The following is a description of a gene set: Neighborhood of HLA-C species: Homo sapiens Human Gene Set: GNF2_HLA_C Neighborhood of HLA-C major histocompatibility complex, class I, C in the GNF2 expression compendium, and this is the list of marker genes: SASH3, CYTIP, STAT6, CD48, INPP5D, SUSD6, FXYD5, TAP1, PHF11, CYBA, WAS, PTPRC, IRF1, SERP1, HLA-A, VAV1, CYBC1, GRK6, ARHGAP45, HLA-G, RAC2, PSD4, TRIM22, ELF4, CORO1A, PTPN6, TAPBP (NCBI Gene Id 6892), TSC22D3, MAX, HCLS1, SIPA1, PSMB10, HLA-B, RIN3, ARHGDIB, LAPTM5, HLA-C, B2M, HLA-F, CD53, ARF6, CORO7, GPSM3, PNRC1, LRCH4, PRR13, HLA-E